Given this list of marker genes AP3M2, TNKS2, PGLYRP1, WAS, KDM5B, TRIP6, PSEN1, MUSTN1, MYO1E, SERF2, ARL4A, RNF11, HMBOX1, METTL27, RMC1, XAB2, DAP, SHE, RAMP1, VPS16, UBAC2, TMEM203, TMEM50B, MOB1A, RGS2, SF1, HECTD1, VPS4B, TNRC6A, TDRD7, ATP11B, CLCN2, ARPC2, PHF8, DNAJB6, DCAF1, WBP1L, AP3B1, RBCK1, EML3, SERINC3, TYROBP, PAK1, INTS13, CTNS, RAB2A, ARHGAP1, SYK, USP25, CBLL1 (NCBI Gene Id 79872), TIPARP, WASF2, EVI2A, DNMBP, RPS3, RAMAC, CTNNB1, SIN3A, TM2D2, CERS4, ZNF654, PARD6G (NCBI Gene Id 84552), OSTF1, PTBP3, VPS41, SORD, MR1, NDRG1, UBE2R2, IL17RB, CDK5, GTF2B, DRC1, MBTPS1, SNX4, FNTB, PHKB, USP33, IRF3, SYCP1 (synaptonemal complex protein 1), CFP, PIP5K1C, ACYP1, IER5, VPS37C, DENND2D, RNF13, PLAUR, SP2 (NCBI Gene Id 96833), TMEM123, GZMA, ITPRID2, NSUN4, SPPL3, USP9X, PCSK7, SLC22A5, SHFL, VPS11, SPIN1, JUNB, DIAPH1, ZDHHC4, CACFD1, FCER1G, SEC31A, SLC35F6, LIN7B, ITIH5, ABL1, ERCC3, ACTN2, MS4A1, NAGA, GADD45B, DEXI, MYO6, KIAA1143, TTYH2, HM13, RHBDL3 (NCBI Gene Id 162494), RSU1, PRKAG1, COQ8A, ARHGAP35, HINFP, LEMD2, SVIL, DIAPH2 (diaphanous related formin 2), PAPSS1, INTS12, RPL30, NFAM1, ATP13A2, MAML2, MROH1, SLC39A11, TAX1BP1, UBE3B, MOB2, GLMP, HAL, TOB1, ZNF394, MAPK11, ARHGDIB, TDP2, PPP3CC (NCBI Gene Id 5533), SUCO, TGIF2, ZNF622 (NCBI Gene Id 90441), PI4KA, RASGRP1, ABHD18, STAG2, WDR45B, NT5C3A, DYNC1H1, GTPBP6, BLTP3B, CD300LD, RAP2C, TSPYL1, AHCTF1, ADI1, DNAI4, HIVEP1 (HIVEP zinc finger 1), ADAP2, RCOR1, FBXO25, LIME1, HIVEP2, ZXDC, MBOAT1, ERAP1, FGF3, IGF2R, AP1M2, S100A11, ARFGEF1, PRDM9, CRNKL1, METTL23, TNKS1BP1, ISG15, ARMCX5, ATP6V1F, ARF5, GRAMD1A, RAB40C, LUC7L2, SNX2, SEMA4F, JCHAIN, SPO11, SUOX, CRAMP1, SLC23A3, BSCL2, SELENOT, here is a description of the gene set: The aim of this study was to employ a systems-level analysis to elucidate gene expression networks operating in the CD4 T-cell responses which underpin human atopic disease. Genes down-regulated in CD4 T cells from non-atopic donors: resting versus stimulated with allergen (house dust mite). from publication Bosco A, McKenna KL, Firth MJ, Sly PD, Holt PG (PMID 19414752) Human Gene Set: GSE14908_RESTING_VS_HDM_STIM_CD4_TCELL_NONATOPIC_PATIENT_DN studied in species Homo sapiens